The following is a description of a gene set: from publication Worschech A, Kmieciak M, Knutson KL, Bear HD, Szalay AA, Wang E, Marincola FM, Manjili MH (PMID 18381452) species: Mus musculus Up-regulated genes defining rejection of mammary carcinoma (MMC) tumors. We have previously shown T-cell-mediated rejection of the neu-overexpressing mammary carcinoma cells (MMC) in wild-type FVB mice. However, following rejection of primary tumors, a fraction of animals experienced a recurrence of a neu antigen-negative variant (ANV) of MMC (tumor evasion model) after a long latency period. In the present study, we determined that T cells derived from wild-type FVB mice can specifically recognize MMC by secreting IFN-gamma and can induce apoptosis of MMC in vitro. Neu transgenic (FVBN202) mice develop spontaneous tumors and cannot reject it (tumor tolerance model). To dissect the mechanisms associated with rejection or tolerance of MMC tumors, we compared transcriptional patterns within the tumor microenvironment of MMC undergoing rejection with those that resisted it either because of tumor evasion/antigen loss recurrence (ANV tumors) or because of intrinsic tolerance mechanisms displayed by the transgenic mice. Gene profiling confirmed that immune rejection is primarily mediated through activation of IFN-stimulated genes and T-cell effector mechanisms. The tumor evasion model showed combined activation of Th1 and Th2 with a deviation toward Th2 and humoral immune responses that failed to achieve rejection likely because of lack of target antigen. Interestingly, the tumor tolerance model instead displayed immune suppression pathways through activation of regulatory mechanisms that included in particular the overexpression of interleukin-10 (IL-10), IL-10 receptor, and suppressor of cytokine signaling (SOCS)-1 and SOCS-3. These data provide a road map for the identification of novel biomarkers of immune responsiveness in clinical trials. Mouse Gene Set: WORSCHECH_TUMOR_REJECTION_UP, and this is the list of marker genes: Ifi204, Mx1, Itk, Tlr4, Ly6f, Gzmb, Tlr6, Cxcl11, Ifna2, Ccl1, Il31, Cxcl1, Cxcl2, Msr1, Tnfrsf4, Lilrb4a, Tnfrsf1b, Il23r, Stat2, Ctla2a, Tcl1b1, Tnfsf11, Mgl2, Ccl9, Il17f, Il5, Ifit1, Stat6, Ccl4, Irf6, Ebf4, Ifitm1, Nkrf, Ackr1, Ccl11 (C-C motif chemokine ligand 11), Cklf, Clec10a, Il7r, Il1rap, Igkv4-90, Ly6a, Ifi202b, Il4i1, Il2rg, Il1a, Lck, Ly6c1, Tagap, Ccl8 (NCBI Gene Id 80561), Ccrl2, Nfat5, Tlx1, Il1b, Il7, Irf4, Fasl, Ifi27, Alcam, Ccl6, Bcl2a1c, Ccr10, Jchain, Il17rb, Ifng, Nfkbiz, Klrd1, Klra9, Ccl22, Nkiras2 (NCBI Gene Id 75157), Ccl5, Il36g